The following is a description of a gene set: species: Mus musculus The process in which the wraps of cell membrane that constitute myelin are laid down around an axon in the central or peripheral nervous system. Mouse Gene Set: GOBP_MYELIN_ASSEMBLY, and this is the list of marker genes: Gnpat, Pmp22, Ckap5, Ercc2, Tppp, Mtmr2, Cd9, Ncmap, Pikfyve, Prx, Pals1, Abca2, Cntn1, Mios, Tlr2, Itgb4, Epb41l3, Tenm4, Mobp, Mag, Dicer1, Nfasc, Pllp, Gpc1, Cntnap1, Ilk (NCBI Gene Id 16202), Ugt8a, Fig4